The following is a description of a gene set: Human Gene Set: GOBP_VASCULAR_ENDOTHELIAL_GROWTH_FACTOR_SIGNALING_PATHWAY The series of molecular signals initiated by vascular endothelial growth factor (VEGF) binding its receptor on the surface of the target cell, and ending with the regulation of a downstream cellular process, e.g. transcription. species: Homo sapiens, and this is the list of marker genes: TNXB, SPRY2, VEGFB, GAB1, SMOC2, NR2F2, KDR, FLT3, ADGRA2, DCN, ITGA5, PDGFRA, ADGRG1, MIR26A1, ROBO1, PIK3CA, NUS1, MIR424 (NCBI Gene Id 494336), SEMA6A, PIK3CB, PTP4A3, VEGFC, NRP2, FOXC1, ITGB1, MYO1C, ADAMTS3, VEGFD, RELA, DLL1, MIR21 (NCBI Gene Id 406991), NRP1, PIK3CD, CADM4, PGF, HRG, VTN, MIR16-1, EMILIN1, FLT4 (NCBI Gene Id 7909), MIR199A1, IL12B, PDGFRB, MIR329-1, IL12A, ANGPT1, VEGFA, CCBE1, PROX1, JCAD, CD63, GREM1, MIR342, FBXW7-AS1, FLT1, ITGB3, DAB2IP, TSPAN32